Given this list of marker genes CTNNB1, TSPAN12, LRP5, NDP, TREX1, BEST1, FZD4, LRRC32, ZNF408, CAPN5, here is a description of the gene set: studied in species Homo sapiens In wound repair, neovascularization (NV) involves the sprouting of new vessels from pre-existent vessels to repair or replace damaged vessels. In the retina, NV is a response to ischemia. The NV adheres to the inner surface of the retina and outer surface of the vitreous. NV are deficient in tight junctions and hence leak plasma into surrounding tissue including the vitreous. Plasma causes the vitreous gel to degenerate, contract, and eventually collapse which pulls on the retina. Since retinal NV is adherent to both retina and vitreous, as the vitreous contracts the NV may be sheared resulting in vitreous hemorrhage or the NV may remain intact and pull the retina with the vitreous resulting in retinal elevation referred to as traction retinal detachment. Human Gene Set: HP_RETINAL_NEOVASCULARIZATION Retinal neovascularization